Given this list of marker genes RPRD1B, PPP1R10, TOX4, SUB1, PPP1CA, WDR82, RPRD1A, here is a description of the gene set: species: Homo sapiens Any process involved in the transition from the initiation to the elongation phases of transcription by a DNA-dependent RNA polymerase, generally including a conformational change from the initiation conformation to the elongation conformation. Promoter clearance often involves breaking contact with transcription factors involved only in the initiation phase and making contacts with elongation specific factors. Human Gene Set: GOBP_PROMOTER_CLEARANCE_DURING_DNA_TEMPLATED_TRANSCRIPTION